Given this list of marker genes FOXP2, OCLNP1, MAP7, SDR42E1, PPT2, MIA2, DMTF1, ENSG00000269210 (novel transcript, antisense to ARHGEF33), RBMS2, CXADR, GPBP1L1, ARL6IP6, SPATS2L, NEK4, PIGV, AKAP5, PTPRK, EPS8L1, FOXC1, C11orf52 (NCBI Gene Id 91894), IFT140, PSMA5, NSUN5, RSPH3, TMEM161B-DT, RPS6KA2, DYNC2LI1, SGCB, KLF3-AS1, SYTL2, CCR9, ENSG00000243081, GLUD1, TJP2, PRR15L, CASTOR3P, SCHIP1, AHI1-DT, CYB5D2, CDK6, FHDC1, JHY, TNFSF10, PLAAT3, TAX1BP3, LRRC19, TGFBR3, TRIOBP, RBM47, EFCAB6, NFIA, RBPMS-AS1, TM7SF3, KDF1, ALDH3A2, SERTAD4-AS1, CRACDL, OSBPL10, FREM2, NFATC2IP, IFT74, CLIC4, MARVELD3, LRRK2-DT, VPS37D, C1orf210, CYB5B, FZD1, PHYHD1 (phytanoyl-CoA dioxygenase domain containing 1), FAT1, AP1S3, EXOC4, CNKSR3, SLC2A13, WSCD1, WFDC2 (WAP four-disulfide core domain 2), GRHL1, MRI1, OPN3, BBS12, PGGHG, VWA5A, FARS2-AS1, TNFSF13, MSLN, TMEM139, IP6K2, LINC03014, KLRK1-AS1, AKAP12, ATXN1L, CHDH, ARHGEF16, NBL1, SUMF2, CTSC, RWDD1, LRPAP1, SAMD13, GIPC2, GOLGA6GP, DAZAP2, FGF14-AS2, CAMTA1, CASP9, MSI2, PLS1, FMO5, TXNIP, EDIL3, SPTLC3, WDR48, STXBP6, TBC1D5, SYNE4, CTAGE9, KCNK5, LMTK2, TRIM38, KIAA2013, MYH8, SPEN-AS1, RGP1, STAG3L3, UPK1B, TMC4, CCL28, EDAR, KCNJ15, KCTD16, CLCF1, DIRAS3, EPN2, GMDS, SIPA1L1, TRIL, BBS4, KLF4 (KLF transcription factor 4), ACAA2, NCBP3, PCLO, PTCHD4, MUC3A, DNAJC1, ICMT, KIF1C, ABHD11, KIF1B (kinesin family member 1B), LCN2 (lipocalin 2), TPK1, LYG1, TMEM43, MON1B, KIF9, RGS12, SHMT1, IRX3, DLG1, SIRT5, SATB2, C6orf132, FAM81B, SATB2-AS1, DNAJC16, DNAJA4, SENP3, CHL1-AS2, PIK3C3, SEMA5A, WDFY3, HYDIN, ERCC6L2-AS1, GLOD4, TNFRSF10C (TNF receptor superfamily member 10c), AIF1L, DPP4, GATAD1, SINHCAF, MIR17HG, BICC1, TRHDE-AS1, WNT5A, LMF1, MUC12-AS1, C12orf75, SDHAF3, ITFG1, PPIA (peptidylprolyl isomerase A), SESTD1, EVC, ODC1, SLPI, RHEX, ESAM-AS1, UBB, CAPN1, CDC42BPG, CUX1, UBXN10, NKAIN3, MMP15, TNFAIP1, SOSTDC1, CCDC30, SMAGP, PRICKLE1, OR7E14P, CDS1, CLSTN1, ELF3 (NCBI Gene Id 2106), EZR, MIR31HG (NCBI Gene Id 554202), ZFP3, COBL, EPHA1, ANXA11, TMEM245, FNDC3A, LRRFIP2, SLC22A2, PAX2, SLC35E2B, NAPEPLD, ITM2B, ZNF747-DT, DBT, CD200, GK5, GIRGL, IL17RB, BCL11A, RELN, SNTB2, BCAR1, NFIB, REV3L, AGO3, OSCP1, CHL1, IL12RB2, SPTLC2, CKMT1B, SLC39A8, POM121, ST14, VAPB, LNP1, PAPPA, KAZN, SHH, CDKN1A, AXIN2, ZNF655, GALNT3, SAPCD1-AS1, ZBTB20 (zinc finger and BTB domain containing 20), SERINC2, ASTN2, CARF, BCL7B, LYPLAL1, DYNLT1, PROM1, PRKAA2, NDFIP2, ADGRA3, AHR, LMTK3, INSYN1, KRT7, IL20RA, MCFD2, BBS2, KITLG, TPMT, WFDC5, HRH1, ADAM10, DNAI4, SLC12A6 (NCBI Gene Id 9990), ADAMTS9-AS1, RND2, CLDN4, RBL2, SEL1L3, SPSB3, SRGAP3, FHL1, VAPA, SCNN1A, BPHL (NCBI Gene Id 83355), VTI1B, SPAG6, SNORA74A, SH3D19 (SH3 domain containing 19), SLC2A9, FUT6, ZBED5-AS1, AOX1, TMEM252, EDNRB, PPL, FAIM, CLDN12, ZSCAN31 (NCBI Gene Id 91921), FBXL16, TVP23B (trans-golgi network vesicle protein 23 homolog B), PAX8, SLC24A1, MED11, PARP4, TMEM125, ADCY9, CLDN7, NUS1P3, AR, ITGB8, CCND2, GBA3, PPM1A, RUNDC3B, MACC1, GPC6, LINC00963, PITPNA, GPRC5C, CRYZ, OCLN, GALNT11, EXO5, CLIC6 (chloride intracellular channel 6), PRSS8, PDSS2, XPC, PRPSAP2, PDF, MITF, ZBTB18, NRXN3, LRRC57, FAAH, SPRYD3, TSPAN1, CCDC198, TCAIM, NLRX1, CPVL-AS2 (CPVL antisense RNA 2), NSUN7, IQCA1, GLB1L, RBP4, MINDY2, CNTN4, FAM110B, NAALADL2, RETREG1, HOXA10-AS, PHACTR2, GATM, PDCD6IP, ZMYND12, CACNB2 (calcium voltage-gated channel auxiliary subunit beta 2), MYL3, IQCH, ACSS2, C6, LMO7, P4HTM, LIME1, ASRGL1, CYP4V2, PTPRD, PLEKHA7, SLC44A4, ILDR1, LRRK2, CCDC57, SLC6A20, CCDC148 (coiled-coil domain containing 148), NUS1, GORASP1, KCNT2, MID1IP1, CFAP69, PKHD1, TJP3, NFAT5, SCMH1, MET (NCBI Gene Id 4233), FOXP4, ENSG00000271858, GTF2I, LINC00899, LSM8, BEND7, FUT3, LINC02888, RAB3IP, DEGS2, AP5M1, DSG2, SUN1, SIK2, ZNF599, TINAGL1, PPFIBP1, ID4, HCG11, here is a description of the gene set: species: Homo sapiens Many tumors, including Hodgkin's lymphoma, are associated with decreased cellular immunity and elevated levels of prostaglandin E(2) (PGE(2)), a known inhibitor of CD4+ T cell activation, suggested to be involved in immune deviation in cancer. To address the molecular mechanisms tumor-derived PGE(2) might have on primary human CD4+ T cells, we used a whole genome-based transcriptional approach and show that PGE(2) severely limited changes of gene expression induced by signaling through the T cell receptor and CD28. This data suggests an interference of PGE(2) at an early step of T cell receptor signaling: indeed, PGE(2) stimulation of T cells leads to inactivation of lck and reduced phosphorylation of ZAP70. Antiapoptotic genes escaped PGE(2)-induced inhibition resulting in partial protection from apoptosis in response to irradiation or Fas-mediated signaling. As a functional consequence, PGE(2)-treated CD4+ T cells are arrested in the cell cycle associated with up-regulation of the cyclin/cyclin-dependent kinase inhibitor p27(kip1). Most importantly, CD4+ T cells in Hodgkin's lymphoma show similar regulation of genes that were altered in vitro by PGE(2) in T cells from healthy individuals. These data strongly suggest that PGE(2) is an important factor leading to CD4+ T cell impairment observed in Hodgkin's lymphoma. Genes down-regulated in CD4+ T lymphocytes after stimulation with prostaglandin E2. from publication Chemnitz JM, Driesen J, Classen S, Riley JL, Debey S, Beyer M, Popov A, Zander T, Schultze JL (PMID 16424048) Human Gene Set: CHEMNITZ_RESPONSE_TO_PROSTAGLANDIN_E2_DN